Given this list of marker genes Myoz2, Myoz3, Myoz1, Tcap, Actn2, here is a description of the gene set: Binding to a member of the FATZ family of proteins, filamin-, actinin-, and telethonin-binding proteins of the Z-disc of striated muscle. FATZ proteins are located in the Z-disc of the sarcomere and are involved in a complex network of interactions with other Z-band components. Mouse Gene Set: GOMF_FATZ_BINDING studied in species Mus musculus